Given this list of marker genes Il21, Gimap5, Clnk, Cd160, Cd96, Gimap3, H2-T23, H2-M3, Cd226, Calhm6, here is a description of the gene set: Any process that contributes to cytokine production by a natural killer cell. studied in species Mus musculus Mouse Gene Set: GOBP_NATURAL_KILLER_CELL_CYTOKINE_PRODUCTION